Given this list of marker genes ARID5B, MCF2L2, TTK, PCDHGA12, FEV, GTF2H2, KHDRBS3, PROX1, IFT74, AGFG1, CDC42SE1, SMARCAD1, WDCP, DPY30, FAM184B, ZNF827, NASP, SFXN5, CCN3, STAM, STX17, H2AC4, DLC1, TUT4, CYREN, ZMPSTE24, FAM167A, COL24A1, NFIA, NUDT9, GMNN, AZIN1, HSF2, KCNK2, KLHL21, PSMA2 (proteasome 20S subunit alpha 2), FBXO36, RPS14, MRAP2, ZNF252P-AS1, NDUFA4, RFC2, MYC, TBC1D2, SNRPC, BCL10, NFU1, TOMM70, RREB1, DDX39B, CLOCK, MOB1B (NCBI Gene Id 92597), SP8, LRP1B, NAP1L5 (nucleosome assembly protein 1 like 5), NKX6-1, H3-3A, HSPA4L, PPP4R3B, SLIT3, MAML3, RPRM, ZNHIT6, LAPTM4A, CWF19L1, COX5B, GTPBP2 (NCBI Gene Id 54676), RBBP5, SUSD5, SMC2, CAV1, KLHL9, AFG2A (AFG2 AAA ATPase homolog A), RUNDC3B, EFNA5, FSTL5, FOXD2 (forkhead box D2), CNTN4, here is a description of the gene set: studied in species Homo sapiens Genes whose DNA methylation differed between primary ALL cells (acute lymphoblastic leukemia) and normal peripheral blood samples. This study examined DNA methylation associated with acute lymphoblastic leukemia (ALL) and showed that selected molecular targets can be pharmacologically modulated to reverse gene silencing. A CpG island (CGI) microarray containing more than 3,400 unique clones that span all human chromosomes was used for large-scale discovery experiments and led to 262 unique CGI loci being statistically identified as methylated in ALL lymphoblasts. The methylation status of 10 clones encompassing genes (DCC, DLC-1, DDX51, KCNK2, LRP1B, NKX6-1, NOPE, PCDHGA12, RPIB9, ABCB1, and SLC2A14) identified as differentially methylated between ALL patients and controls was independently verified. Consequently, the methylation status of DDX51 was found to differentiate patients with B- and T-ALL subtypes (P = 0.011, Fisher's exact test). Next, the relationship between methylation and expression of these genes was examined in ALL cell lines (NALM-6 and Jurkat) before and after treatments with 5-aza-2-deoxycytidine and trichostatin A. More than a 10-fold increase in mRNA expression was observed for two previously identified tumor suppressor genes (DLC-1 and DCC) and also for RPIB9 and PCDHGA12. Although the mechanisms that lead to the CGI methylation of these genes are unknown, bisulfite sequencing of the promoter of RPIB9 suggests that expression is inhibited by methylation within SP1 and AP2 transcription factor binding motifs. Finally, specific chromosomal methylation hotspots were found to be associated with ALL. This study sets the stage for acquiring a better biological understanding of ALL and for the identification of epigenetic biomarkers useful for differential diagnosis, therapeutic monitoring, and the detection of leukemic relapse. Human Gene Set: TAYLOR_METHYLATED_IN_ACUTE_LYMPHOBLASTIC_LEUKEMIA from publication Taylor KH, Pena-Hernandez KE, Davis JW, Arthur GL, Duff DJ, Shi H, Rahmatpanah FB, Sjahputera O, Caldwell CW (PMID 17363581)